Given this list of marker genes CCND1, IQGAP3, RTN4, KDM5B, ZNF703, RREB1, here is a description of the gene set: species: Homo sapiens Human Gene Set: GOBP_POSITIVE_REGULATION_OF_MAMMARY_GLAND_EPITHELIAL_CELL_PROLIFERATION Any process that activates or increases the rate or extent of mammary gland epithelial cell proliferation.